The following is a description of a gene set: studied in species Homo sapiens Human Gene Set: GOMF_QUATERNARY_AMMONIUM_GROUP_BINDING Binding to a quaternary ammonium group, including glycine betaine, choline, carnitine and proline. A quaternary ammonium group is any compound that can be regarded as derived from ammonium hydroxide or an ammonium salt by replacement of all four hydrogen atoms of the NH4+ ion by organic groups., and this is the list of marker genes: PLTP, ANXA13, TKTL2, ESYT1, HACL1, CETP, VDAC2, IGHM, CHMP2A, PITPNM1, CHRNA2, PITPNA, APOA2, PCYT1A, TKT, SERPINA5, PITPNB, VDAC1, OGDH, CHMP3, DHTKD1, PCTP, PITPNM2, JCHAIN, PCYT1B, GPR12, ILVBL, APOC1, OGDHL (NCBI Gene Id 55753), RPE65, RASGRP1, ESYT3, NF1, TKTL1, APOA5, SCARB2, SESTD1, ESYT2, GPR119, APOA4, ABCA1